The following is a description of a gene set: Human Gene Set: GOBP_POSITIVE_REGULATION_OF_CELL_POPULATION_PROLIFERATION Any process that activates or increases the rate or extent of cell proliferation. species: Homo sapiens, and this is the list of marker genes: BCL7A, CEP131, SHOX2, IGFBP2, CD81, HCK, RASAL3, GCNT2, REG3A, TRAF6, ITGB3BP, CIB1, DLG1, MMP2, SHC4 (NCBI Gene Id 399694), CXCR3, HES5, CX3CR1 (NCBI Gene Id 2836), MIR520A, GPR183, TSHR, PRAMEF19, ITGAX (NCBI Gene Id 3687), KMT2D, CAPN1, CNTF, EYA1, JAK2, EDN2, MIR17, ESM1, ZP4 (zona pellucida glycoprotein 4), PNP, RTKN2, FLT3LG, AKT3, TMEM250, TNFRSF11A, RNF187, THBS1 (thrombospondin 1), NTRK3, ROGDI, BMP4, NOTCH2, CAPNS1, HTR2B, MIR372, JAML, ADRA1D, FOSL1, CLEC7A, PTGFR, WNT5A, DNMT1, DERL2, E2F1, GNAI2, KRAS, TBX3, NKX3-1, ERBB4, NRP2, IL12B, TGFA, DISC1, EPHA4, CDKN1A, ADAM10, SLC25A27, CCN4, PRAMEF7, F2R, NKX2-6, PRRX1, TSPO, NRARP, GATA1, NANOGP8, CDKN1B, AKR1C3, GPAM, EDNRB (NCBI Gene Id 3282), STAT5A, STX4, FGF7, FGF8, GHRH, BCL6, CD248, LAMC2, BMP6, IL18, KAT7, MIR548C, MIR23A, TP63, FERMT2 (NCBI Gene Id 10979), SSR1, REG1A, IRS2, GHRL, LDLRAP1, BAMBI, FLT3, FGF20, MIR214, ACTL6A, PRAMEF5, PRTN3, OCSTAMP, PRDX3, IL12RB1, HILPDA, SCX, SOX10, HPSE2, ACER3, SOX8, STX3, IL31RA, HCLS1, EGFL7 (NCBI Gene Id 51162), GFAP, CLDN5 (claudin 5), AIF1, PROX1 (NCBI Gene Id 5629), TSPAN31, POR, FZD3, FAM98B, RPTOR, BMP5, DNAJA2, ID2, PIM1, CCKBR, ID4, SOX15, MIR208A, CTHRC1, TMIGD2, KIF14, SMARCD1, BCL2, FOXG1, ALDH1A2, MAPK14, SPHK2, PRAMEF12, PDCD1LG2, ECM1 (extracellular matrix protein 1), SCG2, CALR, RPS6, CRLF2, FOXP3 (NCBI Gene Id 50943), RARG, CHRNA7 (NCBI Gene Id 1139), PRLR, XCL1 (NCBI Gene Id 92337), CASC11, FLT4, ETV5, RELA, MEIS3, SKP2, CDC6, BRD9, NCK2, FADD, LRG1, IL7, FZR1, KDM1A, CLDN1, PTEN, PRAMEF11, CCN1, XBP1, POU3F3, SERPINB3, PDCD2, PRAMEF1, TIPIN, TSC22D1, AKR1C2, GPBAR1, EXTL3, TNFRSF4, BAD, PRAMEF18, MIR320D1 (NCBI Gene Id 100313896), IL3, FGF6, VIP, MIR222, CDH13, NCCRP1, HPSE, FBLN5, MIRLET7B (microRNA let-7b), MIR10B, APELA, AR, ABL1, GAS6 (growth arrest specific 6), RPS9, GKN1, TNXB, CAV3, ISL1, MYCN, PDPK1, PRKCI, BST1, PTK2, CRLF1, IL12RB2, VCAM1 (NCBI Gene Id 7412), NOTCH3, NOX1, HIPK1, PDF, LIN28A, PDGFA, WDR62, MEF2D, BCL2L1, MATK, CXCL5, CSF2RB, EGR1, HTR1B, MIR509-1, CHRNB2, CCL5, OSM, BNC1, FGF10, CSF3, SCAND3, CSF3R, RIPK2, CNOT6L, CCNA2 (NCBI Gene Id 890), IGF2, ANXA1, TIAM1, MECP2, SLAMF1, MIR200B, PDGFB, MIR1290, CD47, PRKD2, MDK, CD55, ESRP2, FLT1, ITGA4, BIRC6, ITGA2, SRSF6, HMGB2, SMARCD3, CD38, MEF2C, COX17 (NCBI Gene Id 10063), SLC7A5, HPGD, MAPK3, S1PR2, ARNT, UFL1, CDH3 (NCBI Gene Id 1001), CLECL1P, PTPN6 (protein tyrosine phosphatase non-receptor type 6), INSR, AGER, MIR519D, PIK3CD, NF1, GID8, S100B, PRAMEF27 (NCBI Gene Id 101929983), ZNF268, RPA1, SINHCAF, OSMR, MYC, ZFPM2, CSF2 (NCBI Gene Id 1437), TTK, S100A6, MAB21L2, CD28, NPY5R (neuropeptide Y receptor Y5), HRAS, MST1R, HMX2, FNTB, GAREM1, CD40, NOG, CD74, SPTA1, CTF1, KLB, PID1, EAPP, CD4, EPHB2, BCL7C, SPDYA, CRNN, ODC1, GDNF, ASH2L, CYP7B1 (cytochrome P450 family 7 subfamily B member 1), PRAMEF15, HTR1A, ZNF304, RPS3, CNOT8, EMP2 (epithelial membrane protein 2), PURA, TBC1D8, CRKL, SAPCD2, KIT, LRP5, PRAME, PRAMEF4, PTN, MIR20A, HES1, SFRP1, N4BP2L2, FOLR2, IHH, TSPYL5, DBF4B, FLNA, PAXBP1, PRAMEF20, MIR487B, CRIP2, CCL19, CD274, TFAP2B, CORO1A, PDCD6, POU3F2, CR1 (NCBI Gene Id 1378), DLX6, EGR4, MIR181B1, AVPR2, MIR320C2, CSNK2A3 (NCBI Gene Id 283106), TBX20, SLC39A10, TOX, TBX1, FGFR2, THBS4, CCNB1, ACTL6B, LGMN, HMGB1, MAP3K7, NR4A3, PYCARD, MAPK1, TRPM4 (transient receptor potential cation channel subfamily M member 4), PPARD, HLA-DPB1, HTN3, GHSR, IL13RA2, RPL13A, CALCRL, MIR19B1, MIR125B1 (microRNA 125b-1), KDM4C, GHR, TGFB2, PITX2, SMPD3, AGTR1, PPP1R16B, MIR199A1, ADGRG1, FAM98A, MIR27B, LHX2, NME2, IGFBP5, TNFSF12, CDC25B, GREM1, IRAK1, CDK4, HIF1A, MIR146A, CD40LG, MIR21, MYB, MIR711, AQP1, TNFSF13B, FGF18, TRPC5, MYDGF, PRKCH, PIK3R1, HMGN5, MIR495, SDCBP, PLAC8, IQGAP3, HMOX1, MIR301A, CSF2RA, FGF16, TRAF5, VEGFA, FGFR3, WNT10B, IL23A, IGF1, TCIRG1, BICRA, HDAC6, NPY, ACER2 (NCBI Gene Id 340485), KCNA5, RREB1, TSLP, LEP, RNASEH2B, NACC1, NME1, IL2RA, FGF3, NRP1, HLX, IL6ST, ST8SIA1, CDC20, WNT2, EGR3, PLA2G1B, E2F3, NEAT1, PDGFRB, ITGB3, MEIS3P1, CD86, CCR2, DNAJA3 (NCBI Gene Id 94389), GPER1, GRN (granulin precursor), INS, LRP2, MZB1, PDCD10, GDF9, IL4, MIR93, MALAT1, ACTB, NAMPT, MAB21L1, SPHK1, SLC25A5, STAT1, TERT, PIK3CA, NRG1, SCN5A, GLCE, INSM1, CASR, MIR27A, BTK, AKT1, FGFR1 (NCBI Gene Id 84151), TMEM119, SIX2, MMP9, RASSF10, TGM1, RGCC, EPOR, LACRT, MAP3K5, MEIS2, TGFBR3, MFN2, FN1, IL10, NLGN2, ARHGAP5, PRAMEF26, TNFRSF13C, CD276, TYK2, FZD7, NAP1L1, CXCL12, MIR221, TIMP1, PRAMEF2, CDC42, CAMP (cathelicidin antimicrobial peptide), FGF22 (fibroblast growth factor 22), SSBP3, CD80 (CD80 molecule), PRAMEF13, EREG, NKX2-5 (NK2 homeobox 5), TGFBR1, DDR2, SRPK2, MAPK15, PRAMEF33, LAMB1, CNOT6, NFATC2, PHB1, KIF20B, RAB25, PTHLH, RAD51B, EFNB2, NRAS, HHLA2 (HHLA2 member of B7 family), NTF3, RICTOR, CTC1, HAS2, MIR657, REG3G, MIR26A1, F2, TNF, SIRPG, FGF19, MARCKSL1, FOXJ2, MIR204, GPR37L1, CCPG1, CBX8, OTP, SOX9, CUL4A, FGFR4, IL6, JUN, ZP3, GLP2R, TIRAP, EBI3, MIR135B, TCF3, CD24 (NCBI Gene Id 934), TGFB3, CEP43, FOXM1, STAMBP, BCL7B, TPD52 (tumor protein D52), MIR520H, CARD11, AGGF1, PRAMEF8, FBXO5, INSL4, SMARCC1, PAX2, NTN1, BRK1, TBX2, MIR515-1, EDN1, CNBP, CEACAM6, SOX11, IL24, VEGFB, IL34, SLC35F6, TNFAIP3, PTPRC, CDK2, ZAP70, POLD4, PELI1, GDF2, CSNK2A1, PTK2B, PRAMEF14, CSF1 (colony stimulating factor 1), LTA, PRAMEF25, IL9, IL12A, NPM1, PDGFD, BLOC1S2, IGF1R, LYN, WDR77, PRC1, TBRG4, HAVCR2, CXCR2, CARM1, ODAM, MDM2, BICRAL, ATF3, SFRP2, PPP1CC, HLA-E, SIX1, ZMIZ1, SS18, TACR1, BMP10, PTH, SMO, RPL23, CCND2, NR5A2, STAT3, CRIPTO, PDX1, RUNX2, NOP2, PDCL3, MEGF10, MIR126, RPS15A, TGFBR2, AREG, NMBR, TCF7L2, ASPM, SERPINF2, FGF1, PRAMEF9, HTR2A, VIPR1, BMPR1A, CD46, CAV2, IL11RA, PKHD1 (PKHD1 ciliary IPT domain containing fibrocystin/polyductin), IL2, LTBP3, SHH (sonic hedgehog signaling molecule), HDAC4, WDR48, ATXN1, LEF1, FZD9, RBPMS2, CD320, SMARCA2 (SWI/SNF related, matrix associated, actin dependent regulator of chromatin, subfamily a, member 2), MIR130A, CYBA, DDRGK1, FASLG, FGF4 (fibroblast growth factor 4), SASH3, ADAMTS1 (NCBI Gene Id 9510), IL6R, IRAK4, IRS1, PRKCQ, PTH1R, MIR17HG, DPP4, MIR141, TGIF1, RBPJ, PLAG1, IL5RA, GRK5, CCL11, NR2E1, SAAL1, VASH2, BIRC5, NOD2, SELENOK, DLX5, DYNAP, SHMT2, LGALS9, EFNB1, JCAD, FOSL2, MIR30B, SYF2, CGA, RHOG, LEPR (NCBI Gene Id 3953), EPO, CRH, TJP1, ITGB1, SELENON, FOXF1, CCR3, CLCF1, KLF5, KITLG, NGFR, SERPINB7, SYK, IL21, LBH, ITGAV, FSHB, CD209, CCDC117, IFNG, PHIP, CDX2, SIRT1, B4GALT1, TAC1, RAC2, CCL14, PLCG1, BTC, S1PR1, ERN1, SMAD4, SMARCA4, TNC, FOXE3, CFLAR, MIR132 (microRNA 132), SHANK2, ARNT2, APLNR, PML, PROK1, KDM5B, MIR320E, PDGFRA, CSF1R, SHC1, MIR448, FER, MIR499A, NANOG, NODAL, EMC10, YAP1, ZNF580, SLC7A1, MIR320B1, MED1, HPN, CACUL1, SPN, MARCHF7, NES, AVP, ASCL1, FGF17, DLL4, MUSTN1, GAB2, RPRD1B, ERBB3, DMRTA2, CDK1, MIR320B2, CLEC11A, CX3CL1, DCT (dopachrome tautomerase), RARA, SBNO1, IL3RA, CITED1, MIR320C1, MIR10A, APLN, RYK, AVPR1A, EPGN, GHRHR, EDN3, RPS4X, TLR4, MTA3, GATA2, FGF9, ADAM17, MVD, AGT, MPL, NACA (nascent polypeptide associated complex subunit alpha), S1PR3, HNRNPU, BCAR3, CD70, PAX7, MYD88, PDGFC, CD1D, SIRT6, IL1B, SOX4, ACVRL1 (activin A receptor like type 1), ATF2, ILK, CDK6, VAV3, THPO (thrombopoietin), VSTM2A, MIR320D2, FGF2, SEMA5A, NR4A1, ADRA2A, OSR1, NCK1, IL11, AQP11, DISP3, P2RY6, CNOT7, GATA6, ZNF16, PTPRN, HLA-DPA1, HBEGF, PGF, CNTFR, CXCL10 (C-X-C motif chemokine ligand 10), IL1A, MIF, PBXIP1, PRKD1, ANG, EPCAM, CCND1, MIR503, VTCN1, BMI1, LIG4, C5AR1, HLA-DMB, ELL3, MYOCD, TICAM1, ZNF335, ERBB2, BMP2, KDR, HMGA2, WNT7A, PAX6, FCGR3A, TNFSF13, LTF, EZH2, CCAR1, DRD2, CD6, FBLN1, MIR590, CUL3, PRKAA1, ICOSLG, MEIS1, BTNL2, MAZ, PRAMEF6, TLR9, CCL26, FGFBP1, MMP12, WNT3A, COPS9, PLXNB3, TNFSF9, PRAMEF22, MAP2K5, ADM, HLA-A, FGF5, SUZ12, CDC7, CHRD, TEK, BST2, STAT5B, TNFSF4, WNT1, TFRC, IL7R, PAK1, CDON, PRAMEF10 (NCBI Gene Id 343071), F3, VSX2, REG1B (regenerating family member 1 beta), CDCA7L, IL13 (NCBI Gene Id 96500), DHPS, EGF (NCBI Gene Id 1950), KRT6A, PBX1, MLXIPL, SLC25A33, FGF23, MIR29A, ATXN1L, HDAC1, NUS1, MNAT1, MIR101-1, SP1, TGFB1, EGFR, HOXC10, NCKAP1L, CCNE1, GJA1 (gap junction protein alpha 1), PRMT1, OSR2, HSPG2, ZNF703, LIFR, COMP, GLI3, IL15, LIF, PRAMEF17, PRKCA, CTNNB1, DLL1, IL23R, DHX9, LAMC1, VEGFC (vascular endothelial growth factor C), HOXA3, FOXP2, NTRK2, FOXP1, STXBP4, C8orf17, TBX5, NOTCH1, VEGFD, RTN4, LILRB2, ESR1, ITGB1BP1, MIR320A, GLI1, SERTAD1, WWTR1, ELANE, CCL24, FGF21, FCRL3, NMB, HIPK2, CCDC88B, PPP3CA, ATAD5, PITX3 (paired like homeodomain 3), ADA, CD3E, CHP2, HDAC2, IL5, HEY2 (hes related family bHLH transcription factor with YRPW motif 2)